The following is a description of a gene set: studied in species Mus musculus Mouse Gene Set: TABULA_MURIS_SENIS_SPLEEN_CD4_POSITIVE_ALPHA_BETA_T_CELL_AGEING from publication Tabula Muris Consortium (PMID 32669714), and this is the list of marker genes: Lag3, Bcl3, Trp53i11, Cish, Lrch3, Gpsm3, Ptms, Odc1, Sigirr, Cd74, Itm2c, Capg, Rpl13a, S100a6, S100a4, Tnfaip8, H2-Q6, Atxn1, Plp1, Syf2, Fkbp8, Shisa5, Krt14, Selenow, Ifi30, Rab43, Capzb, Cd82, Socs3, Pfn1, Tapbpl, Srgn, Lax1, Smap1, Bcl2a1b, Calm2, Cd3g, Fos, Smco4, Smpdl3a, Cst7, Cxcr3, Trf, Polr2e, Usp53, Tmsb10, Ddit4, Junb, H2-K1 (histocompatibility 2, K1, K region), Socs1, Bmyc, Emc10, Rgs1, Drap1, Aldoa, Tmem160, H2-D1, Apobec3, Itgb5, Sla, Olfml3, Tomm6, Pglyrp1, Ctsz, Laptm4a, Psmb8, Cercam, Ndfip1, Serpina3g, Chi3l1, Gstm1, Pi16, Ier2, Rbm3, Pou2f2, Gabarap, Ikzf2, Krt15, Lat, Cybb, S100a11 (NCBI Gene Id 30048, S100 calcium binding protein A11), Nfkbia, Ptprcap, Ybx1, Cotl1, Maf, Pced1b, Rilpl2, Gimap7, Foxp3, Tnfrsf9, Plin3, Zc3h12d, Gpm6b, Ptpn1, Il2rb, Ube2m, Lrrc41, Tnfrsf18, Timp2, Vasp, Asb2, Ptma, Rnaset2b, Fth1, Ccl5, Phf6, Pdcd1, Ube2n, Calm1, Sik1, H3f3b, Gapdh (glyceraldehyde-3-phosphate dehydrogenase), Pkp3, Crlf2, Ubl3, Fam110a, Arhgdia (Rho GDP dissociation inhibitor alpha), Slc14a1, Srsf5, Cirbp, Tnfrsf4, Icos, Eif5a, Prr13, Stx11, Vmp1, Gpx4, Psme1, Gnas, Csnk2b, Slc38a7, Iigp1, Ccdc80, Tigit (NCBI Gene Id 436418), Ctla4, Ctsb, Cfl1, Cdk2ap2, Arrb2, Apoe, Krt17, Izumo1r, Bhlhe40, Plaat3, Orai1, Batf, Snrnp70, Anxa2, Stx6, Jund, Casp1, Rab37, B2m, Lum, Tnfsf8, Serbp1, Gabarapl2, Ltb, Zfp36l1, Acot7, Tnfrsf1b (NCBI Gene Id 21938), Arf5, Hopx, Nt5e, Itgav, Cebpb, Dusp1, Clic1, Tle5 (NCBI Gene Id 14797), H2az1, Eea1, AW112010, Nrp1, Rgs2, H2-DMa, Lpxn, Ciao2a, Sh2d1a, Traf1, Ubb-ps, Snrpc, Oaz1, Cd81, Syt11, Hnrnpl